The following is a description of a gene set: Mouse Gene Set: GOMF_PROTEIN_GERANYLGERANYLTRANSFERASE_ACTIVITY Catalysis of the covalent addition of a geranylgeranyl (20-carbon isoprenoid) group via thioether linkages to a cysteine residue at or near the C terminus of a protein. studied in species Mus musculus, and this is the list of marker genes: Fnta, Ptar1, Rabggtb, Rabggta, Pggt1b